Given this list of marker genes TWSG1, WFDC1, CIAO3 (NCBI Gene Id 82378), STK32B, ITPR1 (inositol 1,4,5-trisphosphate receptor type 1), PTGIR, BEX1, ADRM1, IL17RB, EGFL7, POU4F1, ISG20, EPCAM, TRAF3IP2, RASAL1, BAALC, ACSM3, ITGB4, PELI2, BAIAP3, VOPP1 (VOPP1 WW domain binding protein), IL5RA, CACNA2D2, ADPRM, KDM4B, CD58, HYAL2, CD244, PSD3, TCN1, SLCO4A1, DISC1, NIT2, RUNX1T1, RCBTB1, ENSG00000275616, H2BC7, LAPTM5, ROBO1, SHC1, TMEM43, MAN1A1, CAV1, H2BC10, ENDOD1, MKNK2, CD19, RASA4, PRAME, SCML2, PALM, H2BC9, KLF11, AP1B1, H2BC5, RGS10, MYRF, PTPN12, ARHGAP1, CLEC5A, DEPTOR, USP10, ARHGEF6, NCALD, SLC25A1, WASHC2C, VAMP5, RPS6KA1, TBXA2R, FBXO38, LCP1, TRH, CD34, HPGDS, CIITA, C15orf39, LAT2, CCND1, IER2, here is a description of the gene set: studied in species Homo sapiens Top 100 probe sets for pediatric acute myeloid leukemia (AML) subtype t(8;21); has AML1 ETO fusion. from publication Ross ME, Mahfouz R, Onciu M, Liu HC, Zhou X, Song G, Shurtleff SA, Pounds S, Cheng C, Ma J, Ribeiro RC, Rubnitz JE, Girtman K, Williams WK, Raimondi SC, Liang DC, Shih LY, Pui CH, Downing JR (PMID 15226186) Human Gene Set: ROSS_AML_WITH_AML1_ETO_FUSION Contemporary treatment of pediatric acute myeloid leukemia (AML) requires the assignment of patients to specific risk groups. To explore whether expression profiling of leukemic blasts could accurately distinguish between the known risk groups of AML, we analyzed 130 pediatric and 20 adult AML diagnostic bone marrow or peripheral blood samples using the Affymetrix U133A microarray. Class discriminating genes were identified for each of the major prognostic subtypes of pediatric AML, including t(15;17), t(8;21), inv(16), MLL chimeric fusion genes, and cases classified as FAB-M7. When subsets of these genes were used in supervised learning algorithms, an overall classification accuracy of more than 93% was achieved. Moreover, we were able to use the expression signatures generated from the pediatric samples to accurately classify adult de novo AMLs with the same genetic lesions. The class discriminating genes also provided novel insights into the molecular pathobiology of these leukemias. Finally, using a combined pediatric data set of 130 AMLs and 137 acute lymphoblastic leukemias, we identified an expression signature for cases with MLL chimeric fusion genes irrespective of lineage. Surprisingly, AMLs containing partial tandem duplications of MLL failed to cluster with MLL chimeric fusion gene cases, suggesting a significant difference in their underlying mechanism of transformation.